Given this list of marker genes Ap2m1, Ap2s1, Ap2a1, Ngf, Ap2b1, here is a description of the gene set: species: Mus musculus electronically inferred by orthology from the curated human pathway part of: Signaling by NTRK1 (TRKA) This event has been computationally inferred from an event that has been demonstrated in another species.<p>The inference is based on the homology mapping from PANTHER. Briefly, reactions for which all involved PhysicalEntities (in input, output and catalyst) have a mapped orthologue/paralogue (for complexes at least 75% of components must have a mapping) are inferred to the other species. Reactome Pathway: Retrograde neurotrophin signalling